The following is a description of a gene set: A speech pattern characterized by a persistently abnormal lack of tone in the voice. Monotonic speech is typically ongoing, lasting throughout the day, but may have a diurnal variation in the pattern, i.e. slower at specific times of the day. Monotonic speech studied in species Homo sapiens Human Gene Set: HP_MONOTONIC_SPEECH, and this is the list of marker genes: LRRK2, FBXO7, SNCA, DNAJC13 (DnaJ heat shock protein family (Hsp40) member C13), VPS35, GBA1 (glucosylceramidase beta 1), EIF4G1, GIGYF2, CWF19L1